Given this list of marker genes BNIP3, BCO2, CCN6, BOK, COL6A1 (collagen type VI alpha 1 chain), PARP1, MTCH2, MTLN, SLC4A11, MAPT, PPA2, SLC25A27, TUSC2, UCP2, PANK2, SLC25A33, OPRD1, GCLM, SLC25A36, GCLC, FZD9, NDUFC2, NNT, BAK1, NDUFS6, MUL1, RTL10, PMAIP1, SMAD3, BAX, PPP2R3C, PID1, LRRK2, PARK7, MYOC, TSPO, PRELID1, STOX1, RNF122, PRDX3, KDR, PPIF, CDKN2A, ABL1, BID, SOD1, MLLT11, SPART, P2RX7, LIPA, PINK1, IFI6, SRC, TSPAN9, KCNQ3, ALB, PYCR1, MIR181B1, GOT1, ADCY10, DCN (decorin), BNIP3L, RACK1, PIP5KL1, VCP, MFN1, BAD (NCBI Gene Id 572), HSH2D, UBB, ABCD1, BCL2L1, ADORA2A, BCL2, SOD2, ATP5IF1, CLIC1, PRKN, ARL6IP5, here is a description of the gene set: Human Gene Set: GOBP_REGULATION_OF_MITOCHONDRIAL_MEMBRANE_POTENTIAL studied in species Homo sapiens Any process that modulates the establishment or extent of the mitochondrial membrane potential, the electric potential existing across the mitochondrial membrane arising from charges in the membrane itself and from the charges present in the media on either side of the membrane.